The following is a description of a gene set: The series of molecular signals mediated by the detection of a hormone. Human Gene Set: GOBP_HORMONE_MEDIATED_SIGNALING_PATHWAY studied in species Homo sapiens, and this is the list of marker genes: GPRIN3, NR1D2, PDE3A, PTPN11, ZMIZ1, TRIM16, NR4A3, GHSR (NCBI Gene Id 92434), HDAC6 (NCBI Gene Id 100820762), NR1H2, TSHR, LATS2, ADIPOQ, HDAC2, CYP26C1, DNAAF4, PARK7, PRCP, ADIPOR1, PPARA, UFM1, TRIM68, RARB, KLF2, METTL21C, IGF1, SSTR4, PRLR, CRKL, EGLN2, RBFOX2, GREB1L, CTBP2, FOXA1, THRB, CARM1, KDM3A, DDX54, ZNF366, CYP26A1, VPS11, CREBRF, VDR, DEFA3, PGRMC2, ERRFI1, CRHBP, TRH (NCBI Gene Id 7200), ESRRB, KDM1A, PML, PMEPA1, ALDH1A2, NCOR1, SNW1, PTH, CYP26B1, GTF2H1, CGA, TRIM24, CYP24A1, SHQ1, STRN3, NR3C1, TP63, CLOCK, CST11, NR0B1, CCDC62, BRCA1, PIM1, SLC27A1, RARG, FKBP4, SST, PIAS2, CYP7B1, TBX1, RARA, GPHB5, AGRP, SP100, THRA, POU4F2, DEFA1B, PRL, NR2E1, AR, CALR, DDRGK1, PPARD, FOXH1, HMGA2, SAFB, DEFA1, GPER1, RXRA, CNOT1, ZNF536, PAGR1, PAQR7, KDM5D, RWDD1, ESR1, ABHD2, ESR2, NCOA4, RXFP2, CRHR1, APPL1, NCOA3, EZH2, ACTN4, OSTN, LHB, DAB2, UFL1, ADIPOR2, PGR, RHOA, NR1H3, PTF1A, USP26, FSHR, PPP5C, ZDHHC7, SIRT1, NR5A2, UBA5, FOXP1, LBH, ESRRA, VPS18, CYP27B1, REN, RHOXF1 (Rhox homeobox family member 1), TADA3, TGIF1, DHRS3, PADI2, TRIP4, CRY2, SCGB2A2, UBE3A, CRY1, ZBTB7A, SNAI2, IL23R, ISL1, CRHR2, GHR, LANCL2, NR2C1, PRMT2, UBR5, MIR208A, LATS1, MN1, RNF14, PAK1, KANK2, RXRG, DAXX (death domain associated protein), YWHAH, ASXL1, UFSP2, SSTR3, TRERF1, CDK12, ASIP, NR3C2, CRH, TAF7, CNOT2, SSTR2, RXRB, PRAME, PAQR8, KDM4C, NCOA1, PKN1, SRC, NODAL, BMAL1, ESRRG, PER1, TCF7L2, APPL2, EP300, PARP1, SCGB2A1, NKX3-1, JAK2, SKP2, NR5A1, PPARGC1B, MED1 (mediator complex subunit 1), NCOR2, TAF1, TCF21, CGB3, PLPP1, OR51E2, NR1D1, SFRP1, CNOT9, CALCOCO1, RELA, TMF1, GHRL, RXFP1, DDX5, NEDD4, LMO3, AKR1C3, LHCGR, DDX17, CSNK2B, RNF6, UCN2, PHB2, UCN3, SMARCA4, PPARG, WBP2, SSTR5, KMT2D, ACSL1, SRARP, SSTR1, SAFB2, HDAC1, GHRHR, HEYL, PHB1, NR2E3